The following is a description of a gene set: Reactome Pathway: Miro GTPase Cycle part of: Signaling by Rho GTPases, Miro GTPases and RHOBTB3 This event has been computationally inferred from an event that has been demonstrated in another species.<p>The inference is based on the homology mapping from PANTHER. Briefly, reactions for which all involved PhysicalEntities (in input, output and catalyst) have a mapped orthologue/paralogue (for complexes at least 75% of components must have a mapping) are inferred to the other species. studied in species Mus musculus electronically inferred by orthology from the curated human pathway, and this is the list of marker genes: Rhot2, Mfn2, Trak1, Myo19